Given this list of marker genes PLCZ1, ACRBP, GSG1, ATF7IP, H2AJ, AKAP3, CLEC12B, CAPZA3, SOX5, LINC02366, DNAI7, LRRC23, RASSF8, here is a description of the gene set: Human Gene Set: KORKOLA_EMBRYONAL_CARCINOMA_DN species: Homo sapiens from publication Korkola JE, Houldsworth J, Chadalavada RS, Olshen AB, Dobrzynski D, Reuter VE, Bosl GJ, Chaganti RS (PMID 16424014) Genes from the 12p region that were down-regulated in embryonic carcinoma tumors compared to normal tissue. Adult male germ cell tumors (GCTs) comprise distinct groups: seminomas and nonseminomas, which include pluripotent embryonal carcinomas as well as other histologic subtypes exhibiting various stages of differentiation. Almost all GCTs show 12p gain, but the target genes have not been clearly defined. To identify 12p target genes, we examined Affymetrix (Santa Clara, CA) U133A+B microarray ( approximately 83% coverage of 12p genes) expression profiles of 17 seminomas, 84 nonseminoma GCTs, and 5 normal testis samples. Seventy-three genes on 12p were significantly overexpressed, including GLUT3 and REA (overexpressed in all GCTs) and CCND2 and FLJ22028 (overexpressed in all GCTs, except choriocarcinomas). We characterized a 200-kb gene cluster at 12p13.31 that exhibited coordinated overexpression in embryonal carcinomas and seminomas, which included the known stem cell genes NANOG, STELLA, and GDF3 and two previously uncharacterized genes. A search for other coordinately regulated genomic clusters of stem cell genes did not reveal any genomic regions similar to that at 12p13.31. Comparison of embryonal carcinoma with seminomas revealed relative overexpression of several stem cell-associated genes in embryonal carcinoma, including several core stemness genes (EBAF, TDGF1, and SOX2) and several downstream targets of WNT, NODAL, and FGF signaling (FGF4, NODAL, and ZFP42). Our results indicate that 12p gain is a functionally relevant change leading to activation of proliferation and reestablishment/maintenance of stem cell function through activation of key stem cell genes. Furthermore, the differential expression of core stem cell genes may explain the differences in pluripotency between embryonal carcinomas and seminomas.